The following is a description of a gene set: The chemical reactions and pathways involving any of the compounds secreted by the thyroid gland, largely thyroxine and triiodothyronine. species: Homo sapiens Human Gene Set: GOBP_THYROID_HORMONE_METABOLIC_PROCESS, and this is the list of marker genes: DUOX2, SULT1A1, SLC26A7, DUOXA2, SULT1A3, CTSK, GCNT4, CRYM (crystallin mu), MED1, IYD, SULT1B1, HPN, SLC5A5, SLCO1C1, DIO1, DIO2, TPO, PAX8, DIO3, SULT1A4, TG, CPQ, CTSB, SULT2A1, FOXE1, GATA3, DUOXA1, SLC16A10, SLC16A2, CGA, DUOX1